The following is a description of a gene set: studied in species Homo sapiens Human Gene Set: GOMF_NUCLEIC_ACID_CONFORMATION_ISOMERASE_ACTIVITY Catalysis of a reaction that alters the conformation of a nucleic acid., and this is the list of marker genes: CHTF8, DDX10, BRIP1, SMARCAL1, EIF4A3 (eukaryotic translation initiation factor 4A3), XRCC6, DNA2, DDX46, DDX41, DDX39A, DDX11L8, TOP3B, DHX30, CHD8, DHX32, CHD1L, DHX37, CHD2, RAD54B, BTAF1, DHX57, DDX19B, SNRNP200, DDX52, DDX51, AQR, TOP2A, MCM2, TOP1MT, YTHDC2, DHX15 (NCBI Gene Id 1665), DDX49, TDRD9, ZNFX1, CHD3, PIF1, MCM5, SMARCA2, DDX42, RECQL, TOP2B, DICER1, ERCC6L, FBH1, FMR1 (NCBI Gene Id 5421), RAD54L, RAD51, SUPV3L1, EIF4B, DDX18, MCM9, SMARCAD1, DSCC1, RFC4, IGHMBP2, DHX9, DHX58, EIF4A1, DDX12P, MOV10L1, RECQL5, CHD4, TTF2, CHTF18, ZGRF1, ERCC6, EIF4H, ERCC2, DDX31, DDX17, SMARCA1, MRE11, DDX11, SLFN11, DHX33, DDX55, DHX16, DHX29, DHX8, SHPRH (SNF2 histone linker PHD RING helicase), DDX25, G3BP1, WRNIP1, HELZ, FANCM, UPF1, DDX20, DHX36, TOP3A, DDX39B, SETX, RIGI, SMARCA5, RAD54L2, MOV10, FXR1, DDX24, MCM8, CHD6, RFC3, DDX3X, RTEL1, DDX60L, RUVBL1, CHD9, DDX21, ZRANB3, DDX47, DHX40, SPO11, HLTF, TP53, IFIH1, BLM, DHX38, XRCC5, DDX53, CHD5 (NCBI Gene Id 26139), NAV2, HELZ2, ASCC3, POLQ, ATRX, DDX3Y, DQX1, MCM7, RAD50, DDX43, HELLS, DDX19A, HELB, DDX23, RUVBL2, HELQ, DDX59, EIF4A2, CHD7, CHD1, DDX4, DHX34, TWNK (twinkle mtDNA helicase), DDX60, MCM6, EP400, DDX5, DDX28, MTREX, RFC2, HFM1 (NCBI Gene Id 374992), DHX35, ERCC3, ERCC6L2, RFC5, DDX56, SKIC2, DDX54, DDX6, SMARCA4, DDX50, SRCAP, DDX1, TDRD12, MCM4, RECQL4, MCM3, WRN, TOP1, DDX27